The following is a description of a gene set: part of: DNA Repair Reactome Pathway: Mismatch Repair species: Mus musculus This event has been computationally inferred from an event that has been demonstrated in another species.<p>The inference is based on the homology mapping from PANTHER. Briefly, reactions for which all involved PhysicalEntities (in input, output and catalyst) have a mapped orthologue/paralogue (for complexes at least 75% of components must have a mapping) are inferred to the other species. electronically inferred by orthology from the curated human pathway, and this is the list of marker genes: Pold4, Msh6, Msh3, Pold1, Pms2, Lig1, Pcna, Rpa1, Pold2, Msh2